Given this list of marker genes Il2, Ubac2, Zic3, Zbtb26, Dlg5, Atf7, Zfp449, Tex19.1, Acsl3, Acnat1, Ocrl, Tab3, Fgf14, Itga6, Mtcl1, Plin2, Lin28b, Itgam, Fbxl20, Wipf3, Rho, Or51e1, Onecut2, Rorc, Farp2, Gm16130, Lrrc1, Ywhab, Elovl6, Eaf1, Vangl1, Dhcr24, Ano3, Khdrbs1, Cxcl15, Ube2e3, Cks2 (NCBI Gene Id 66197), Glis2, Ap1s3 (adaptor-related protein complex AP-1, sigma 3), Rab11fip4, Trak2 (trafficking protein, kinesin binding 2), Fbxl18, Ackr2, Atp6v0e2, Cstf1, Rab39, Aipl1 (aryl hydrocarbon receptor-interacting protein-like 1), Dmc1, Ncam1, Palld, Ranbp6, Ankrd44, Carhsp1, Ttc24, Kcna5, Sspn, Fen1, Edem3, Ap3m1, Pfn2, Zbtb4, Map3k3, Dnmt3b, Fmnl2, Nid1, Treh, Ppm1b, Dpy19l1, here is a description of the gene set: studied in species Mus musculus Mouse Gene Set: MIR_6927_3P Genes predicted to be targets of miRBase v22 microRNA mmu_miR_6927_3p in miRDB v6.0 with MirTarget v4 prediction scores > 80 (high confidence targets). from publication Chen Y, Wang X (PMID 31504780)